The following is a description of a gene set: species: Homo sapiens from publication Zhang Y, Jamaluddin M, Wang S, Tian B, Garofalo RP, Casola A, Brasier AR (PMID 12719586) Human Gene Set: ZHANG_ANTIVIRAL_RESPONSE_TO_RIBAVIRIN_DN Respiratory syncytial virus (RSV) is a mucosa-restricted virus that is a leading cause of epidemic respiratory tract infections in children. RSV replication is a potent activator of the epithelial-cell genomic response, influencing the expression of a spectrum of cellular pathways, including proinflammatory chemokines of the CC, CXC, and CX(3)C subclasses. Ribavirin (1-beta-D-ribofuranosyl-1,2,4-triazole-3-carboxamide) is a nontoxic antiviral agent currently licensed for the treatment of severe RSV lower respiratory tract infections. Because ribavirin treatment reduces the cytopathic effect in infected cells, we used high-density microarrays to investigate the hypothesis that ribavirin modifies the virus-induced epithelial genomic response to replicating virus. Ribavirin treatment administered in concentrations of 10 to 100 micro g/ml potently inhibited RSV transcription, thereby reducing the level of RSV N transcripts to approximately 13% of levels in nontreated cells. We observed that in both the absence and the presence of ribavirin, RSV infection induced global alterations in the host epithelial cell, affecting approximately 49% of the approximately 6,650 expressed genes detectable by the microarray. Ribavirin influences the expression of only 7.5% of the RSV-inducible genes (total number of genes, 272), suggesting that the epithelial-cell genetic program initiated by viral infection is independent of high-level RSV replication. Hierarchical clustering of the ribavirin-regulated genes identified four expression patterns. In one group, ribavirin inhibited the expression of the RSV-inducible CC chemokines MIP-1 alpha and -1 beta, which are important in RSV-induced pulmonary pathology, and interferon (IFN), a cytokine important in the mucosal immune response. In a second group, ribavirin further up-regulated a set of RSV- and IFN-stimulated response genes (ISGs) encoding antiviral proteins (MxA and p56), complement products, acute-phase response factors, and the STAT and IRF transcription factors. Because IFN-beta expression itself was reduced in the ribavirin-treated cells, we further investigated the mechanism for up-regulation of the IFN-signaling pathway. Enhanced expression of IFI 6-16, IFI 9-27, MxA/p78, STAT-1 alpha, STAT-1 beta, IRF-7B, and TAP-1-LMP2 transcripts were independently reproduced by Northern blot analysis. Ribavirin-enhanced TAP-1-LMP2 expression was a transcriptional event where site mutations of the IFN-stimulated response element (ISRE) blocked RSV and ribavirin-inducible promoter activity. Furthermore, ribavirin up-regulated the transcriptional activity of a reporter gene selectively driven by the ISRE. In specific DNA pull-down assays, we observed that ribavirin enhanced RSV-induced STAT-1 binding to the ISRE. We conclude that ribavirin potentiates virus-induced ISRE signaling to enhance the expression of antiviral ISGs, suggesting a mechanism for the efficacy of combined treatment with ribavirin and IFN in other chronic viral diseases. Genes up-regulated in A549 cells (lung carcinoma) upon infection with RSV (respiratory syncytial virus) and down-regulated by further treatment with ribavirin., and this is the list of marker genes: AADAC, CCL3, CYP1B1, JUN, TUBA4A, CAV2, ZFHX3, IL15, RRAS2, RANGAP1, TNFRSF9, UBE2D3, PLK2, GATA3, AHR, PTGER2, TFDP1, SERPINE1, DUSP10, CCL4, PPP1R3C (NCBI Gene Id 5507), CDC14A, FGF2, FOXO3, CXCR3, SOCS2, RGS20, ARL4A, IRF5, TUBB2A, RALGDS, RAPGEF3, GEM, CFLAR, VEGFC, SMAD1, PPP3CC, MAP4K5, CENPC, ITPR3, ATP2B1, AXL, IL2RG, IFNB1, NCF2